The following is a description of a gene set: studied in species Homo sapiens Human Gene Set: GOBP_ANATOMICAL_STRUCTURE_MATURATION A developmental process, independent of morphogenetic (shape) change, that is required for an anatomical structure to attain its fully functional state., and this is the list of marker genes: SPINK5, CATSPER3, BRCA2, EBP, ADAMTS12, HDAC6, RPS6KA2, GATA2 (NCBI Gene Id 84724), RXFP2, LHX6, RAB24, FBXO41, SLFN14, LEP, TDRD1, CCDC39, DIAPH3, PRKACA, TMIGD1, FLVCR1, SIX3, EXT1, GAL, SNX10, TRIP13, ATP6AP2, MAEA, TCP11X1, CX3CL1, MMP2, SLC24A4, WEE2, BRD1, OOSP2, TCP11, TRPC4AP, RBPJ, DEFB1, IGF1, TAL1, BSPH1, RUNX2, LGI4, ACVRL1, SPINK1, CDH3, FOXA1, FGFR1, KDM1A, KCNQ3 (NCBI Gene Id 3786), SIRT2, IQCF1, ELSPBP1, P2RX5, LTF, SEMA4D, VEGFA, RERE, ANKS1A, TMPRSS12 (NCBI Gene Id 283471, transmembrane serine protease 12), NPR2, TUT4, SCLT1, CLN5, PHOSPHO1, FUT6, PDE3A, RND1, TDRKH, BCL11A, SCARF1, CDKN1C, C1QL1, CCL19, NRCAM, CATSPER2, YTHDF2, PTH, FAM210B, WNT5A, MECP2, ADAMTS7, G6PD, SEMG2, DDIT3, ROPN1L (rhophilin associated tail protein 1 like), CATSPER4, FEM1B, FERMT1, BFSP1, LRRK2, MBTPS2, TGFB2, ASCL1, RYR1, CDK5R1 (cyclin dependent kinase 5 regulatory subunit 1), CCNB1, CCR6, ACTL6B, SOX10, MTCH1, REN, GDF11, WNT1, CEBPA, MOS, KDR, TBX6, NF1, ZBTB16, ZBTB7A, TDRD7, HOXA5, PICK1, ADAM7, ZAR1, EPHA8, ANGPTL8, ALDH1A2, HBZ, DLD (dihydrolipoamide dehydrogenase), NSUN2, AXL, IRX5, WNT10B, HOXB13, H3-3A, KLF2, CATSPERD, RET, GHRHR, ABHD2, GATA3, HID1, FEV (FEV transcription factor, ETS family member), AKR1B1, PLA2G3, CTNNB1, PPARG, BAIAP3, KIF14, C3, GH1, SEMG1, PLA2G10, AURKA (NCBI Gene Id 8465), L3MBTL3, ROPN1, HEATR3, BMP2, GREM1, FAM20C, CABYR, B4GALT6, PTBP3, RAC2, BFSP2, PLD6, KCNIP2, CNTNAP2, B4GALT5, CNTN2, PGR, DCHS1, ARCN1, RAC3, APP, RFX3, EPAS1, NR4A2, HES5 (NCBI Gene Id 388585), ID2, HIF1A, RB1, CDH5, KCNE1, ROPN1B, CX3CR1, FBXO5, CLEC7A, TUBB8, SOX18, SNX19, NTN4, GBA1, ZAR1L, TDRD6, EPO, BCL2, ADGRB3, SLC26A3 (NCBI Gene Id 1811), FZD5, H3-3B, EDN1, BHLHA15, THBS3, CDC25B, TUSC2, SHB, NKX6-1, RHOA, IL15, HES1, BAP1, CNGB1, TMEM79, GLDN, CCL21, EDNRA, CDK5R2, C2CD6 (C2 calcium dependent domain containing 6), XYLT1, RFLNA, TFCP2L1, CCDC154, FOXJ1, RECK, SPTBN4, RHEX, TCP11X2, MAP3K13, MSX2, SOX8 (NCBI Gene Id 30812), GALNT3, TUT7, NOM1, DAZL, EDNRB, BNC1, PPP2R1A, RAC1, PAX2, WASHC5, PTPRN, IFT80, VSX1, DMC1, EPB42, FARP2, WDR77, SPG21, NGF, AGRN, SRRM4 (serine/arginine repetitive matrix 4), PTH1R, EREG, ANG, SLC26A6, IER3IP1, CATSPERZ, KCNB1, ERCC2, EFCAB9, TDRD5, CBFB, NEMP1, CATSPERE, PLXNB1, TGFB1 (transforming growth factor beta 1), LSM14B, REC8, GPAT4, LYL1, IHH, ACTN3, LCN6 (lipocalin 6), CFTR, IL21, SMIM45, PCSK4, RFLNB, BTK, CEND1, MYOC, DAG1, NPPC, S1PR1, XBP1, TRIM58, SLC22A14, FOXO3, FGFR3, PAEP, C1QA